The following is a description of a gene set: Human Gene Set: WP_VITAMIN_D_METABOLISM Vitamin D metabolism studied in species Homo sapiens, and this is the list of marker genes: CYP2R1, RXRA, PTH, CYP27A1 (NCBI Gene Id 1593), DHCR7 (7-dehydrocholesterol reductase), GC, CYP27B1, CYP24A1, RXRB, VDR